The following is a description of a gene set: species: Mus musculus Mouse Gene Set: GOBP_ETHANOLAMINE_CONTAINING_COMPOUND_METABOLIC_PROCESS The chemical reactions and pathways involving ethanolamine (2-aminoethanol) and compounds derived from it., and this is the list of marker genes: Chka, Gdpd3, Abhd4, Gdpd1, Moxd2, Napepld, Naaa, Gde1, Moxd1, Dbh